The following is a description of a gene set: Mouse Gene Set: GOBP_DE_NOVO_CENTRIOLE_ASSEMBLY_INVOLVED_IN_MULTI_CILIATED_EPITHELIAL_CELL_DIFFERENTIATION Centriole assembly in which a centriole arises de novo by a process involving an electron-dense structure known as a deuterosome, rather than by duplication of an existing centriole, and occurring as part of multi-ciliated epithelial cell differentiation. studied in species Mus musculus, and this is the list of marker genes: Deup1, Plk4, Cep152, Cep63 (centrosomal protein 63), Ccdc78